Given this list of marker genes EGR1, KRT14, IL6, ACAN, KRT13, DSC2, CDK5, VTN, RARG, MAP3K14 (NCBI Gene Id 9020), NINJ1, SMO, TGFB1, TGFB2, ITGB7 (integrin subunit beta 7), RFC2, EDN2, KRT10, IL13 (interleukin 13), NOTCH4, IFI6, here is a description of the gene set: Ultraviolet B irradiation initiates and promotes skin cancers, photo-aging, and immune suppression. In order to elucidate the effect of these processes at the level of gene expression, we used cDNA microarray technology to examine the effect of ultraviolet B irradiation on 588 cancer-related genes in human keratinocytes at 1, 6, and 24 h post-irradiation with a mildly cytotoxic dose of ultraviolet B (170 mJ/cm(2)). The viability of the irradiated keratinocytes was 75% at 24 h post-irradiation. Various cytokeratins and transcription factors were up-regulated within 1 h post-irradiation. After 6 h, expression of a variety of genes related to growth regulation (e.g. p21(WAF1), notch 4, and smoothened), apoptosis (e.g. caspase 10, hTRIP, and CRAF1), DNA repair (ERCC1, XRCC1), cytokines (e.g. IL-6, IL-13, TGF-beta, and endothelin 2), and cell adhesion (e.g. RhoE, and RhoGDI) were altered in human keratinocytes. These data suggest the changes in a cascade of gene expression in human keratinocytes occurring within 24 h after UVB exposure. Although the roles of these cellular genes after UVB-irradiation remain to be elucidated, microarray analysis may provide a new view of gene expression in epidermal keratinocytes following UVB exposure. from publication Murakami T, Fujimoto M, Ohtsuki M, Nakagawa H (PMID 11532376) species: Homo sapiens Genes down-regulated in primary keratinocytes at 6 h after UVB irradiation. Human Gene Set: MURAKAMI_UV_RESPONSE_6HR_DN